Given this list of marker genes PLA2G4A, PLA2G4F, MEF2C, EZH2, CRIP1, SLC9A1, MDM2, CDKN1B, ABCB1, TP53, RPL23, here is a description of the gene set: studied in species Homo sapiens Human Gene Set: GOBP_CELLULAR_RESPONSE_TO_ANTIBIOTIC Any process that results in a change in state or activity of a cell (in terms of movement, secretion, enzyme production, gene expression, etc.) as a result of an antibiotic stimulus. An antibiotic is a chemical substance produced by a microorganism which has the capacity to inhibit the growth of or to kill other microorganisms.